The following is a description of a gene set: Mouse Gene Set: GOBP_RESPONSE_TO_ACIDIC_PH studied in species Mus musculus Any process that results in a change in state or activity of a cell or an organism (in terms of movement, secretion, enzyme production, gene expression, etc.) as a result of a pH stimulus with pH < 7. pH is a measure of the acidity or basicity of an aqueous solution., and this is the list of marker genes: Pkd2l1, Kcnk3, Lgmn, Scnn1g, Gpr31b, Slc9a1, Kcne1, Rab11b, Kcnk9, Gpr4, Chp1, Serpinf1, Scnn1b, Slc38a3, Pkd1l3, Gpr65, Asic2, Asic1, Pck1, Scnn1a, Kcnk4, Kcnk1, Src, Ctss, Rab11fip5, Gpr151, Sst, Asic3, Gip, Trpv1 (NCBI Gene Id 22366)